The following is a description of a gene set: Effects of SOCS3 on the transcriptional response of bone marrow-derived macrophages to IL-6. Fetal liver cells from SOCS3+/+ or SOCS3-/- embryos were used to reconstitute recipient mice. Donor derived bone marrow from these mice was differentiated to macrophages. Macrophages were either unstimulated, or stimulated for 100 or 400 minutes with 10 ng/ml IL-6. studied in species Homo sapiens from publication Lang R, Pauleau AL, Parganas E, Takahashi Y, Mages J, Ihle JN, Rutschman R, Murray PJ (PMID 12754506) Human Gene Set: GSE411_WT_VS_SOCS3_KO_MACROPHAGE_IL6_STIM_100MIN_UP Genes up-regulated in macrophages treated by IL6 for 100min: wildtype versus SOCS3., and this is the list of marker genes: PRR5, ITGAX, EHD4, RIOK3, GLRX2, PLCD1, MAN1B1 (NCBI Gene Id 51697), DHFR, GCDH, GSTT2 (NCBI Gene Id 91334), ATP5MC3, CASS4 (Cas scaffold protein family member 4), FOSB, CD2BP2, SDHD, ECI2, MTX2, CD300C, CENPF, SLC22A23, ATP6AP2, CLPTM1, CHAC1, NCAPH, CRIP2, YARS1, RNASEH2B, CHI3L1, FKBP2, HAUS1, CD8A, ZNHIT1, PELO, RNF187, CAMK2A, CDCA5, ACADVL, DYM, ATP5PO (NCBI Gene Id 539), IMMT, IQGAP2, TM9SF1, DDIAS, IFRD2, PRIM1 (NCBI Gene Id 5557), TOMM20, ELP5, PSMD1, DNAJC1, TMCC1, TRAIP, APIP, CYB5A, CD300A, F2RL1, MRPL55, CEBPB, ZNF473, ADIPOR1, PPP1R10, PSMB7, FOXM1, UHRF1, ARIH1 (ariadne RBR E3 ubiquitin protein ligase 1), CACNA1H, MDH2, PKM, RILPL1, SLC39A4, ARFIP2, SLC12A4, GUK1, RAB2A, ANAPC13, PFDN6, TMEM140, AK3, ABHD14A, BATF3, ABI2, PPM1H, TPI1, EDF1, RNH1, SIVA1, DNAJC13, PYCR2, SHCBP1, SRGN, HSPB6, MRPS10, CLTB, TCF19, GNL3, LSR, BASP1, ATP6V0C, P2RY14, UNC50 (NCBI Gene Id 25972), CYTIP, SMPD1, EIF4EBP1, IGLC7, DLGAP5, LAPTM4A, TIMM17B, DDX50, UHRF2, GNB4, ADAM8, SLCO4A1, ZCCHC18, JMJD8, HCFC2, SHB, HS2ST1, IPO11, PSMD7, CELA1, ASCC3, VAT1, AARSD1, LCORL, ROPN1L, ACTR10, AP2B1, BUB1 (NCBI Gene Id 699), EZH2, TRPM2, PLK4, UQCRB, NDUFAF7, MCM6, CACNB3, BRCA1, PAQR9, LTF, TRABD, NSDHL, CANX, RAB3D, SLC38A10, GMPS, GNE, ZFAND3, DNA2, MAB21L3, HSPA1B, LRR1, EIF2S1, CDK5RAP3 (CDK5 regulatory subunit associated protein 3), ALAD, CDKN2B, ACER3, CACNA1E, ARF4, TOR2A, DPAGT1, PADI4, TSPO, DNAJC10, TF, SLC11A1, NCAPD2, OGFOD3, AURKA, RECQL4, ERH, TGFBI, NMT1 (N-myristoyltransferase 1), CHTF18, MSANTD4, ALPK2, RPLP0, ESPL1, CEP192, CDK2AP2, TMEM263, ETFDH, GOLPH3L, TOR1B, PAPSS1, FOXN2, ALDH18A1, DDX56, NUSAP1, ATOH8, LMF2, IFITM2, EIF6, ZDHHC14, KIFC1, HBS1L, NAA20, PSMD6, DNAJB11 (NCBI Gene Id 51726), PDCL, FAM117A, CAPN5, NDUFB8